Given this list of marker genes Rhog, Klc2, Kif5a, Klc3, Rac1, Cdc42, Ktn1, Klc4, Kif5b, Klc1, Rhoa, here is a description of the gene set: studied in species Mus musculus RHO GTPases activate KTN1 Mouse Gene Set: REACTOME_RHO_GTPASES_ACTIVATE_KTN1